The following is a description of a gene set: Human Gene Set: HP_CLITORAL_HYPOPLASIA Clitoral hypoplasia Developmental hypoplasia of the clitoris. studied in species Homo sapiens, and this is the list of marker genes: SNORD115-1, ORC4, SNORD116-1, TBC1D20, PWRN1, FZD2, OCA2, POC1A, B3GLCT, CDC6, DVL1, CDT1, PPP2R3C, RAB18, HERC2 (NCBI Gene Id 8924), PORCN, PWAR1, ORC6, ORC1, CDC45, ROR2, MKRN3, NDN, RAB3GAP1, RAB3GAP2, GMNN, SIM1, NPAP1, DVL3, MAGEL2, WNT5A, SNRPN